The following is a description of a gene set: CHD6, CHD7, CHD8 and CHD9 make up subfamily III, based on their orthology to the founding member in Drosophila, Kismet. Like subfamily I and II proteins, subfamily III proteins have tandem N-terminal chromodomains and a SNF2 ATPase domain, but also have additional C-terminal motifs including a Brahma-Kismet (BRK) domain, a SANT motif, and a DNA-binding region. The function of the BRK domain, so named because of its identification in the Drosophila Brahma and Kismet proteins, is not elucidated but it may play a role in binding CTCF. Like other CHD proteins, subfamily III is implicated in regulation of transcription, proliferation and repair of DNA damage. Although CHD6-9 are 50-54% identical, they appear to have distinct biochemical characteristics and to play non-redundant biological roles. studied in species Homo sapiens Reactome Pathway: CHD6, CHD7, CHD8, CHD9 subfamily part of: CHD chromatin remodelers, and this is the list of marker genes: CHD7, PB2, DKK2, H2BC12, H2BC12L, CHD8, H2AC7, CTCF (NCBI Gene Id 10664), CHD9, H2BC9, H3C1, NP, H2BC1, AXIN2, H2BC4, NFE2L2, H2AB1, H2BC26, H2AC20, H4C1, H2AJ, PA, H2BC3, NKD2, IGF2, H2AC18, CREBBP, H2AX, CHD6, CTNNB1, H2BC17, H2BC21, EP300, H2BC15, NQO1, NS, H2BC13 (NCBI Gene Id 8340), H3C15, H2BC14, H2AC14, FAM124B, H2AZ2 (NCBI Gene Id 94239), H2AC6, H2BC5, H2BC11, WDR5, PB1, MAFK (MAF bZIP transcription factor K), H2AC4, H3-3A